The following is a description of a gene set: studied in species Homo sapiens The actin-mediated process that results in the contraction of the apical end of a polarized columnar epithelial cell. Human Gene Set: GOBP_APICAL_CONSTRICTION, and this is the list of marker genes: LUZP1, FRMD6, ROCK1 (NCBI Gene Id 6093), EPB41L5, CCDC88C